The following is a description of a gene set: Human Gene Set: GOCC_LAMELLIPODIUM A thin sheetlike process extended by the leading edge of a migrating cell or extending cell process; contains a dense meshwork of actin filaments. species: Homo sapiens, and this is the list of marker genes: TWF2, DUSP22, EPHA2, APC, RAC2, ENAH, CARMIL1, CASP8, CDH2, CTNNB1, VIL1, ITSN1, PKD2, NF2, PLXND1, APBB1IP, SPATA13 (spermatogenesis associated 13), CAPG (capping actin protein, gelsolin like), SCYL3, PAK1, ANTXR1, CORO1C, RAC3, APBB2, NRBP1, DGKZ, PDXP, STX2, CDC42BPA, PHACTR4, HAX1, AIF1, ABI3 (NCBI Gene Id 51225), SLC9A1, PIEZO1, AJUBA, ABI1, ARHGEF6, ALS2, MYO10, ABLIM1, SORBS2, SSH1, FER, AVIL (NCBI Gene Id 80056), FLOT1, ABLIM3, WASL, CARMIL3, AKT1, CDH1, RNH1, PARVB, CDK5 (cyclin dependent kinase 5), FSCN1, CTNNA3, RAC1, PLEKHH2, SH3BP1, STX3 (syntaxin 3), RAPGEF3, CTTNBP2NL, CAPRIN1, PKN2, MEFV, PABPC1, RAB13, AMOT, ACTB, FAP, APBB1, RAB3IP, PPP1R9B, PLEKHG5, TRPV4, NHS, ARHGAP31, FERMT2, MYO9B, BCAR1, ARHGEF7, DAG1, ITGB1BP1, DPP4, ARPIN, SHTN1, PIP5K1A, CAPZB, TIAM2, NME2 (NME/NM23 nucleoside diphosphate kinase 2), WASF3, DOCK8, P4HB, ACTR3, GIT1, ROCK1, INPPL1, DDX3X, PODXL, CORO1A, FAT1, PDLIM4, RDX, FGD5, FAM89B, CCDC88A, DBNL, LIMK1, EVL, APC2, PDPN, FGD2, SPEF1, PTPRO, KPTN, NCKAP1, UNC5C (NCBI Gene Id 8633), KITLG, DPYSL3, ARPC2, CLRN1, MCC, IQGAP2, FGD1, ABI2, SNX1, STX4, FLOT2, SH3RF1, RUFY3, CORO1B, WASF1, SYNE2, RAPH1, PALLD, TUBB3, PTPRM, ACTA2, SRGAP2, ARPC5, MTSS2, CIB1, SLC39A6, RHOA, ACTC1, PLEK2, TSC1, GDPD2 (glycerophosphodiester phosphodiesterase domain containing 2), ITGAV, VASP, CTNNA1, CSPG4, ARPC3, CTTN, MYH10, KCNA2, PTK2B, STMN2, PHPT1, WASF2, PIK3CA, FGD6, VAMP7, CFL1, PLCG1, ITGB1, BAIAP2, APP, FGD4, GSN, ITGB3, MYO1G (NCBI Gene Id 64005), ABITRAM, KLHL2, SNX2, ANGPTL3, PTPN13 (protein tyrosine phosphatase non-receptor type 13), ACTA1, CDC42BPB, NEDD9, TESK1, TESC, SCRIB, CTNNA2, PSTPIP1, CD177, SWAP70, CARMIL2, CYFIP1, MYLK, FGD3, ACTG2, FSCN3, PXN, BRK1, CD44, IGF2BP1, PEAR1, ARAP3, WASH3P, ILK (NCBI Gene Id 55522), PLCE1